Given this list of marker genes Phlda1, here is a description of the gene set: electronically inferred by orthology from the curated human pathway studied in species Mus musculus part of: G2/M Transition This event has been computationally inferred from an event that has been demonstrated in another species.<p>The inference is based on the homology mapping from PANTHER. Briefly, reactions for which all involved PhysicalEntities (in input, output and catalyst) have a mapped orthologue/paralogue (for complexes at least 75% of components must have a mapping) are inferred to the other species. Reactome Pathway: Interaction between PHLDA1 and AURKA